Given this list of marker genes COL2A1, ERI1, COL11A1, MECOM, TLK2 (tousled like kinase 2), ABCC8, IHH, TBX2, KCNJ11, ASXL3, GLI3, SIN3A, KNSTRN, NOG, NARS2, GDF5, TBX3, SNRPN, FBXW11, PIK3CD, KDM5B, here is a description of the gene set: species: Homo sapiens Abnormal 4th finger morphology Human Gene Set: HP_ABNORMAL_4TH_FINGER_MORPHOLOGY